Given this list of marker genes Il18, Jak2, Rasal3, Il12b, Zbtb7b, Il23a, Tyk2, here is a description of the gene set: Any process that modulates the frequency, rate or extent of natural killer T cell proliferation. Mouse Gene Set: GOBP_REGULATION_OF_NK_T_CELL_PROLIFERATION species: Mus musculus